Given this list of marker genes NGF, BRAF, YWHAB, NTRK1, KIDINS220, RAP1A, CRK, here is a description of the gene set: ARMS-mediated activation Human Gene Set: REACTOME_ARMS_MEDIATED_ACTIVATION studied in species Homo sapiens